Given this list of marker genes Tnf, Slc6a1, Slc6a6, Gja1, Dpysl2, Slc25a13, Slc25a22, Cck, Grm7, Apba1, Trpv1, Arl6ip5, Kcnk2, Slc7a13, Best1, Grin2b, Ttyh3, Grik1, Cln8, Grm1, Arhgef11, Slc17a6, Grm2 (glutamate receptor, metabotropic 2), Slc6a13, Slc1a1 (NCBI Gene Id 319379), Slc25a12, Itgb1, Arl6ip1, Gabbr1, Trh, Nf1, Kcnk1, Slc17a7, Adora2a, Gipc1, Slc1a6, Ntsr1, Slc1a5, Snca, Rab3gap1, Slc1a7, Avp, Slc1a3, Hrh3, Epm2a, Slc7a14, Slc1a2, Dtnbp1, Slc38a6, Slc38a2, Nr3c1, Stxbp1, Ttyh2, Bdnf, Pianp (PILR alpha associated neural protein), Il1b, Kmo, Pak1, Slc3a1, Syt4, Slc12a2, Myo6, Nherf1, Ttyh1, Prkg1, Slc25a18, Kcnj10, Slc17a8, Psen1, Avpr1a, Slc1a4, Slc7a11, Ntrk2, Septin2, Adora1, Abat, Kcnj8, Htr6, Per2, Abcc8, Npy5r, Vps54, Il1rn, Slc32a1, Gnat2, P2rx7, here is a description of the gene set: The directed movement of acidic amino acids, amino acids with a pH below 7, into, out of or within a cell, or between cells, by means of some agent such as a transporter or pore. Mouse Gene Set: GOBP_ACIDIC_AMINO_ACID_TRANSPORT species: Mus musculus